The following is a description of a gene set: A lasting absence of total IgG and total IgA and total IgM in the blood circulation, whereby at most trace quantities can be measured. studied in species Homo sapiens Human Gene Set: HP_AGAMMAGLOBULINEMIA Agammaglobulinemia, and this is the list of marker genes: IGLL1, BLNK (NCBI Gene Id 29760), TTC7A, PIK3R1, CD79B, IGHM, SLC39A7, CDCA7, TCF3, IKBKB, TIMM8A, IL2RG, HELLS, FNIP1, CARD11, CIITA, SPI1, BTK, CD79A, LRRC8A